The following is a description of a gene set: species: Mus musculus Genes positively differentially expressed in cell type: CD8+ T cell upon treatment with cytokine: IFN-κ in mouse lymph nodes in vivo. from publication Cui A, Huang T, Li S, Ma A, Pérez JL, Sander C, Keskin DB, Wu CJ, Fraenkel E, Hacohen N (PMID 38057668) Mouse Gene Set: CUI_T_CELL_CD8_IFNK_RESPONSE_UP Cytokines mediate cell-cell communication in the immune system and represent important therapeutic targets. A myriad of studies have highlighted their central role in immune function, yet we lack a global view of the cellular responses of each immune cell type to each cytokine. To address this gap, the authors created the Immune Dictionary, a compendium of single-cell transcriptomic profiles of more than 17 immune cell types in response to each of 86 cytokines (>1,400 cytokine-cell type combinations) in mouse lymph nodes in vivo. A cytokine-centric view of the dictionary revealed that most cytokines induce highly cell-type-specific responses. For example, the inflammatory cytokine interleukin-1β induces distinct gene programmes in almost every cell type. A cell-type-centric view of the dictionary identified more than 66 cytokine-driven cellular polarization states across immune cell types, including previously uncharacterized states such as an interleukin-18-induced polyfunctional natural killer cell state., and this is the list of marker genes: Ms4a4b, H2-T23, Slfn8, Tspo, Stat1, Shisa5, Tcof1, Tapbp, Ifit1bl1, Slfn1, Trim12a, Ifi206 (interferon activated gene 206), Dtx3l, Zbp1, Samd9l, Bst2, Ifi203, Rigi, Ifi214, Irf7, Trim25, Epsti1, Ddx60, Psmb10, Ifi47, Ly6e, Ifi213, Trim30d, Eif2ak2, Isg20, Ppa1, Psmb9, 9930111J21Rik2, Uba7, Ifit3, Rsad2, Psme2, Dhx58, Trim12c, Oas3, Gbp9, Ifit3b, Rnf114, Helz2, Psmb8, Mx1, Chmp4b, Plac8, Sp100, Daxx (NCBI Gene Id 13163), Rtp4, Herc6, Parp9, Isg15, Ifit1, Oasl2, Samhd1, Trafd1, Slfn5, Smchd1, Usp18, Sp110, Igtp, Ifi35, Phf11c, Pml, Gbp7, Mitd1, Irgm1, Ifi27l2a, Slfn2, Oasl1, Mndal, Lgals3bp, Cmpk2, Ifi209, Psme1, Rnf213, Ddx24, Ccnd2, Ifih1, Ly6a, Ifi208, Parp14, Trim30a, H2-T22, Phf11b, Xaf1